The following is a description of a gene set: Genes predicted to be targets of miRBase v22 microRNA mmu_miR_136_5p in miRDB v6.0 with MirTarget v4 prediction scores > 80 (high confidence targets). species: Mus musculus Mouse Gene Set: MIR_136_5P from publication Chen Y, Wang X (PMID 31504780), and this is the list of marker genes: Slit2, Mtmr7 (NCBI Gene Id 54384), Jazf1, Smarcd1, Syne1, Man1c1 (NCBI Gene Id 230815), Mrps33, Prl3a1 (prolactin family 3, subfamily a, member 1), Nxpe3, Kbtbd6, Atl3, Gdf6, Glcci1, Phldb2, Zfp354a, Cxcl3, Kmt2a, Bptf, Slc7a3, Etf1, Hoxc10, Trpc4ap, Ppp2r2a, Map3k1, Ubtd2, Rpusd4, Rnf152, Pcdh19, Zfp710 (zinc finger protein 710), Mtmr4, Mab21l1, Cntn5, Zfp827, Sla2, Tspyl3, Braf, Ctnnbip1, Psd3, Prpf38b, Cttnbp2, Nr1h5, Extl3, Rap2c, Cpeb2, Sema4c, Vamp4, Radil, Prdm16 (PR domain containing 16), Spty2d1, Psme4, Itsn1, Irak2, Stt3b, Atrn, Lzts3, Chrdl1, Tmod3, Pigk, Mdm1, Rif1, Xpo7, Ppp1r18, Slc19a1, Cbx4, Cnot7, Sgip1, Bcl7b, Cdkn2aip, Magt1, Ccdc7a